The following is a description of a gene set: Human Gene Set: REACTOME_TRANSCRIPTIONAL_REGULATION_BY_THE_AP_2_TFAP2_FAMILY_OF_TRANSCRIPTION_FACTORS Transcriptional regulation by the AP-2 (TFAP2) family of transcription factors studied in species Homo sapiens, and this is the list of marker genes: CDKN1A, DEK, SUMO1, VEGFA, WWOX, PITX2, TFAP2B, YEATS4 (NCBI Gene Id 8089), APOE, KCTD15, CITED2, UBE2I, TGFA, NPM1, CGB5, CITED1, CITED4, NOP2, TFAP2D, ATAD2, CREBBP, CGB3, KDM5B, YY1, HSPD1, ESR1, TFAP2C, TFAP2E, TFAP2A, MYBL2, EGFR, CGA, CGB8, MYC, EP300, ERBB2, KCTD1, KIT